Given this list of marker genes Zdhhc17, Mpc2, 2610005L07Rik, Ppard, Barhl1, Accsl, Gm16136, Gm15504, Pten, Ino80dos, Dmxl2, Bub3, Trappc2b (trafficking protein particle complex 2B), Bcl9, Prkacb, Ecpas, Pdlim7, Tmc6, Gxylt1, Gbx2, Lhx3, Pgbd5, Gm10642, Glra1, Atf4, Ctnnb1, Rph3a, Strit1, Ext2, Enah, Dele1, Ncdn, Oxsm, Usp35, Lrrc40, Pcca, Synj2, 1110025M09Rik, Stkld1, Mrpl14, Zkscan8, Dclk2, Ssc4d, Naxd, Pcna, Mir7b, Mindy1, Fzd7, Prex1, Fetub, Mien1, Cth, Ctps2, 0610038B21Rik, Nhsl2, 0610009L18Rik, Smyd5, Nnt, 0610009E02Rik, Rbm15b, Plin5, Mettl21c, Ppp4r1, Fry, B4galt7, Kdm2a, Hells, Gtf2h5, Snapin, Bphl, Cmip, Dnlz, Ppp3cb, 4931422A03Rik, Dnal1, Spire2, Dcaf6, Atp5mc3, 1110018N20Rik, Hnrnpl, Lcor, Pura (NCBI Gene Id 70733, purine rich element binding protein A), Smarcc1, Usp31, Fbln2, B230319C09Rik, Tmem63b, Cop1, Fbxl12os, Cyb5r4, Xkr7, Dcaf1, Fev, Pim3, Mixl1, Kctd10, Pdia6, 1810013D15Rik, Niban2, Kif13b (NCBI Gene Id 77105), Tet3, Mtag2, Ints12, Itm2b, Tnc, Zfp236, Pde6d, Gmnn, Disp2, Acaca, Ppp1r12c, Accs, Ric8b, Gm14057, Kansl1, Msmo1, Wdr41, C430014B12Rik, Gm13562, Srgap2, Pbx3, Gm10010, Ube4b, Igf2, Rex1bd, Tmem59, Ubxn2a, Endod1, Septin2, 4930558J18Rik, Sdhaf2, Nmrk2, Entpd3, Hnrnpf (heterogeneous nuclear ribonucleoprotein F), Kmt2c, Gm23969, Ppp1r26, Gm12063, Gm13161, Atp13a3, Coprs, 1700017N19Rik, Hrh3, Lrp11, Serac1, Rpl7a, Oat, Eefsec (eukaryotic elongation factor, selenocysteine-tRNA-specific), Thrap3, Dnmt3a, Rest, Ngly1, Vkorc1, Wdr82, Gm15693, Esyt1, Cspg4, Duxf1, Gstcd (glutathione S-transferase, C-terminal domain containing), Mx2, Cops7b, Mir6935, Cacng2, Anxa11, Atp11b, Tent4b, Hsp90aa1, Vps37c, Gtf2f1, Dipk1a, Ddrgk1, Akain1, Ptpra, Gm25878, Ndufb9, Supt6, Pan3, Ddr1, AV099323, Kctd18, Tatdn1, Usp28, Tma7, Dph6, Hikeshi, Epb41l5, Nrip1, Tob1, Snrpa1, Asphd1, Unc13a, Mff, Triqk, Lipt2, 1700086O06Rik, Ubc, Olig3, Ccdc171, Dpp8, Phospho2, Txlng, Tex56, Ubac1, Kctd21, Eif4enif1, Actl6b, Niban3, Nfkbiz, Tceanc2, Ern1, Qsox1, Znfx1, Nphp4, Srrm3, Samd1, Zfp644, Snapc4, Arid5a, Qki (NCBI Gene Id 66145), Tcp11, Klf7, Mfhas1 (malignant fibrous histiocytoma amplified sequence 1), Plekho1, Eri3, Cdc42se1 (NCBI Gene Id 99930), Acat1, Lhfpl4, Sccpdh, Setbp1, Stip1, Actg1, Myo1b (NCBI Gene Id 98177), Crebbp, Kcnh6, Gars1, Lemd2, Hint2, Btbd6, 1700066M21Rik, A930029G22Rik, Stat3, Actb, Rlig1, Dynlt2b, Fgfr1, Atf7ip, Trappc3, Lrrc56, Ep300, Fbxw2, Rybp, Msh5, Usp32, Cfap210, Mex3d, Ubn2 (NCBI Gene Id 73019), Gm9870 (NCBI Gene Id 100856880), Med22 (NCBI Gene Id 99421), Dynll2, Aldh9a1, Yif1a, AU040320, Gm7546 (predicted gene 7546), Ube3b, Cacng3, Scrt1, Surf4, 1700105P06Rik, Reep3, Arl4c, Kcnb1 (NCBI Gene Id 16500), Sez6l2, Mir6236, Zfas1, Vps72, Galnt6, Arhgap10, Klf2, Dchs2, Ccdc51, Kyat3, here is a description of the gene set: Genes containing one or more binding sites for (Klf15) in their promoter regions (TSS -1000,+100 bp) as identified by GTRD version 20.06 ChIP-seq harmonization. Mouse Gene Set: KLF15_TARGET_GENES species: Mus musculus from publication Yevshin I, Sharipov R, Kolmykov S, Kondrakhin Y, Kolpakov F (PMID 30445619)